Given this list of marker genes Rack1, Abl1, Kif20b, Rictor, Cyrib, Dock8, Arfgef1, Flot2, Wdpcp, Gata3, Rufy3, Abl2, Ripor2, Cfl1, Shtn1, Gsn, Rap1b, Cdh5, Plekhg3, Krit1, Ankfn1, Kank1 (KN motif and ankyrin repeat domains 1), here is a description of the gene set: Any process that modulates the frequency, rate or extent of establishment of cell polarity. Mouse Gene Set: GOBP_REGULATION_OF_ESTABLISHMENT_OF_CELL_POLARITY species: Mus musculus